Given this list of marker genes Shc1, Frs2, Plcg1, Grb2, Ngfr, Pik3r1, here is a description of the gene set: studied in species Mus musculus Mouse Gene Set: GOMF_NEUROTROPHIN_TRKA_RECEPTOR_BINDING Binding to a neurotrophin TRKA receptor.